The following is a description of a gene set: Any process that modulates the frequency, rate or extent of the chemical reactions and pathways resulting in the breakdown of glycogen. species: Mus musculus Mouse Gene Set: GOBP_REGULATION_OF_GLYCOGEN_CATABOLIC_PROCESS, and this is the list of marker genes: Ppp1r3d, Phkg1, Ppp1ca, Hmgb1, Ins1, Ppp1r3c, Ins2, Ppp1cb, Phkg2, Phka1 (NCBI Gene Id 270629), Ppp1r3b, Adra1b, Adcy10, Phkb (phosphorylase kinase beta), Ppp1r3e